The following is a description of a gene set: Mouse Gene Set: GOBP_ANIMAL_ORGAN_MORPHOGENESIS species: Mus musculus Morphogenesis of an animal organ. An organ is defined as a tissue or set of tissues that work together to perform a specific function or functions. Morphogenesis is the process in which anatomical structures are generated and organized. Organs are commonly observed as visibly distinct structures, but may also exist as loosely associated clusters of cells that work together to perform a specific function or functions., and this is the list of marker genes: Pou3f4, Tcf15, Rtn4, Bsx, Flt1, Tbx5, Rorb, Sox17, Myo6, Mir875, Barx2, Nrg3, Foxe3, Cxcr4, Palb2, Acvr1, Stat1, Dll4, Edn1, Pbx2, Srsf6, Kdr, Yy1, Vps51, Hoxb13, Uncx, Hesx1, Myc, Etv4, Hmx2, Fst, Gnat1, Fzd6, Myo3a, Adamts16, Wnt2b, Pcdha9, Foxo3, Ank, Hs2st1, Capn1, Tnfrsf11b (NCBI Gene Id 18383), Slc39a3, Xirp2, Sod1, Rara, Tbx3, Nfkb1, Crkl, Kdm6a, Kcnj8, Irx5 (Iroquois homeobox 5), Hoxa2, Tbr1, Pml, Ntng2, Acan, Dvl2, Gli3, Slitrk6, Pdgfa, Egln1, Wdr72, Krt13, Thrb, Pthlh, Odaph, Col5a1, Gnat2, Myf6, Gata3, Ncor2, Nrg1, Lims2, Grhl3, Spry1 (NCBI Gene Id 24063), Acta2 (actin alpha 2, smooth muscle, aorta), Pdgfc, Col13a1 (collagen, type XIII, alpha 1), Aqp1, Megf8, Grhl2, Rln1, Ajap1, Miat, Dchs1, Hoxd9, Met, T, Ctsd, Ilk, Six4, Ext1, Mef2d, 2610005L07Rik (NCBI Gene Id 436177), Agtr2, Slc26a4, Bmp2, Prdm1, Bbs4, Nle1, Plag1, Bcl11b, Mir217, Fras1, Lzts2, Atf2, Wnt3, Olfm3, Ntng1, Col6a1, Enam, Tead2, Men1, Esrp2 (epithelial splicing regulatory protein 2), Hs3st3a1, Gba1, Wnt11, Ssu2, Hoxa9, Apcdd1, Col2a1, Prkcb (NCBI Gene Id 319718), Stk40, Shh, Alpl, Fgfr1, Kcnq1, Pitx3, Rela, Trip11, Flvcr1, Mesp2, Ptk7, Traf6, Twist1, Id1, Cpb2, Th, Yap1, Wnt10a, Cav1, Cyp26b1, Nos3, Sfrp2, Man2a1, Fgfr2, Slit2, Hoxd3, Sulf2, Ereg, Slc1a1, Aldh1a1 (NCBI Gene Id 320092), Mapk8ip3, Foxf1, Rab33b, Cthrc1, Bmi1, Nrp2, Sox12, Btbd7, Npy1r, Stil, Sp1, Vps33b (vacuolar protein sorting 33B), Mir216a, Zfp950, Sema3c, Gjb6 (gap junction protein, beta 6), Lbx1, Gdf11, Neurod1, Ttn, Trpm1, Myh6, Clrn1, Hand2os1, Htt, Vax2os, Ccdc40, Tfap2a, Satb2, Foxn4, Cdkn2a, Lrig3, Ttc39c, Mir96, Dlx5, Rab23, Aldh1a2, Dvl3, Jag1, Mir20a, Fzd2, Ikzf1, Ncoa3, Myo3b, Megf11, Trex1, Ifitm5, Aplnr, Twsg1 (NCBI Gene Id 71539, twisted gastrulation BMP signaling modulator 1), Wnt16, Map2k2, Crygb, Prrx2, Plekha1, Hoxd13, Rpl38, Sparc, Il6, Ctsl, Hps1 (NCBI Gene Id 54334), Tymp, Hey2 (hairy/enhancer-of-split related with YRPW motif 2), Ntf5, Fam20a, Fgr, Lhfpl5, Ddr1, Bmp5, Col11a2, Dlg1, Foxp2, Kdm2b, Hottip, Lamb3, Chuk, Ccm2l, Mmp14, Mks1 (NCBI Gene Id 380718), Tnfsf11, Ceacam2, Lrig1, Sdk2 (NCBI Gene Id 75715), Gsc, Intu, Foxn3, Vegfc, Zfp335, Myf5, Cntf, Emx1, Ihh, Sp6, Tbx19 (T-box 19), Gli1, Med1, Nipbl, Ar, Has2, Insig1, Tnc, Fbn1, Foxa2, Ltf, Nab2, Ptprq, Stat6, Htr2b, Mdm2, Bmp6, Arl6, Tgfb3, Gata4, Pkd1, Esr2, Ifng, Pappa2, Lama1, Elf3, Wls, Foxi3, Pax8, Tnnt2, Cited2 (Cbp/p300-interacting transactivator, with Glu/Asp-rich carboxy-terminal domain, 2), Dlx2, Sox8, Pds5a, Fmn1, Psen1, Ntrk2, Ush2a, Gcnt4, C2cd3 (NCBI Gene Id 277939), Gcnt1, Zic3, Abr, Maged1, Cdsn, Lhx9, Itga2, Itgav, Mtor, Klk1b1, Hlx, Lama3, Eif4a3, Atf4, Rpgrip1l, Shank3, Lamc3, Dlg5, Naglu, Fbxw11, Tgm1, Tnf, Grk1, Rac1, Celsr1, Pafah1b1, Fli1, Prom1, P2rx7, Slc40a1, Tmtc3, Eva1a, Kras, Bcl2l11 (BCL2 like 11), Irx3, Msn, Tpm1, Alx4, Fancc, Sfrp4, Ppp1r13l, Myo5a, Matn1, Pbx1, Slc4a2, Cer1, Hoxa1, Ppargc1b, Mrtfb, Csrnp1, Tmem119, Hoxb5, Ceacam1, Mmp2, Chst11, Tgfbr3, Sirt6, Nab1, Col1a2, Bsg, Lef1, Pnpla6, Sall1, Samd7, Foxc1, Tdrd7 (tudor domain containing 7), Arid2, Pitx2, Adarb1 (NCBI Gene Id 76716), Clrn2, Meis2, Sufu, Tshz1, S1pr1, Wnk4, Rflnb, Hand1, Wnt6, Lamb1, Osr2, Rest, Mical2, Foxj1 (NCBI Gene Id 15223), Tmem215, Npnt, Thy1, Insr, Npy2r, Lipa, Atp6v1b1 (NCBI Gene Id 269766), Tfap2b, Sox5, Muc19, Ccl2, Ankrd24, Slc4a7, Ltbp3, Fancd2, Plau, Bmpr1a, Efnb2, Zfand5, Sfrp1, Rbm15, Bmpr1b, Klk4, Nherf1, Chad, Nf2 (NCBI Gene Id 18016), Nr4a3, Nr5a2, Sox11, Hs3st3b1, Mir23a, Mib1, Cdon, Sostdc1, Hnf1a, Atp2b2, Gata6, Pkp2, Col8a1, Meis1, Asb2, Tulp3, Hoxb8, Zfp157, Igf1r, Tgfa, Robo2, Cluap1, Asxl1, Cfc1, Tmed2, Slc8a1, Exoc4, Tet2, Six1, Rpgr, Ntn5, Trp63, Snai1 (NCBI Gene Id 98875), Hacd1, Sp7, Mir143, Pou2f1, Hoxa11, Pou4f3 (POU domain, class 4, transcription factor 3), Ascl5, Hoxd11, Dkk1, Hdac1, E2f4, Taf10, Mylk2, Nrl, Ahr, Cdh2, Rspo2, Ctns, Mmp16, Slc6a4, Tmem100, Atp8a2, Sec24b, Fgf10, Clic5, Tcap, Idua, Alx1, Mir182, Sox2, Rbm20, Rs1, Bmpr2, Twist2, Angpt1, Kdm5b (NCBI Gene Id 98723), Prkra, Zhx2, Dio3, Smtnl1, Cnga3, Serpinb5, Apc, Tgm2, Nrp1, Ovol2, Folr1 (NCBI Gene Id 14275), Parva, Cdc42, Ryk, Atg9a, Zfpm2, Thbs1, Wnt8a, Amelx, Col8a2, Ntn4, Pbrm1, Frs2, Foxg1, Chd7, Itpr1, Gabrr2, Axin1, Myh7, Fgl1, Perp, Sox4, Atoh1, Hmgn1, Dnah11, Eif4a3l2, Tecta, Olfm1, Ush1c, Gas1, Fat1, Tmt1a3, Ephb4, Nppc, Pdgfb, Sik3, Tbx2, Vsx2, Smad3, Errfi1, Plxnd1, Pten, Inppl1, Tbx1, Ctsz, Slc39a1, Mir145a, Otx2, Mapk14, Setdb2 (SET domain, bifurcated 2), Efemp1, Rbpms2, Npy5r, Col10a1, Tspear, Hoxb7, Foxf2, Lrrk2, Ptprm, Med12, Mir18, Ush1g, Lctl, Hyal1, Bmp10 (bone morphogenetic protein 10), Por, Comp, Sycp2, Cdx1, Sobp (NCBI Gene Id 78400), Actn3, Actg2, Wnt8b, Calb1, Pax9, Ripply1, Stau2, Mef2c, Lrp4, Pax4, Gja5, Acp5 (NCBI Gene Id 11433), Cela1, Slit3, Atg9b, Hhex (NCBI Gene Id 15243), Scube2, Triobp, Phlda2 (pleckstrin homology like domain, family A, member 2), Myl2, Tek, Mir452, Eda, Gzf1, Fat4, Synpo2l, Sav1, Egfr (NCBI Gene Id 13649), Fkbp1a, Hmga2, Inhba, Crb2, Foxe1, Fhl2, Recql4, Sapcd2, Igf2, Fgfr3, Sh3pxd2b, Magee2, Timeless, Stat5a, Hoxa7, Rxfp1, Hoxa4, Ephb2, Odam, Adgrg6, Tmem67, Col9a1, Edar, Wdr48, Kdm2a, Shox2, Tprn, Psen2 (NCBI Gene Id 98295), Pkd2 (polycystin 2, transient receptor potential cation channel), Grcc10, Lemd2, Klk5, Aqp3, Ndp, Grem1, Tfap2c, Jag2, Cst5, Hoxb1, Lamc1, Irx2, Snx10, Fbn2, Hpn, Spry2, Rarb, Gnas, Wnt5b, Dlx1as, Otx1, Alms1, Spag6l, Tmie, Mir124a-2 (NCBI Gene Id 723950), Tuba1a (tubulin, alpha 1A), Bcl2, Commd5, Id2, Tiparp, Cd44, Enpp1, Fgf1, Tmem107, Dscam, Mfap2, Mybpc3, Nr3c1, Hoxd8, Ring1, Bhlhe22, Rnls, Ski, Fgf8, Fosl2, Large1 (LARGE xylosyl- and glucuronyltransferase 1), Hyal2, Nkx2-3 (NK2 homeobox 3), Lama2, Hdac2, Ephb1, Cebpb, Nfib, Gaa, Zfpm1, Rxra, Zfp640, Pcnt, Hspg2, Frem1, Stim1, Prrx1, Nfix, Megf9, Dnaaf1, Lamb2 (laminin, beta 2), Myl3, Agtpbp1, Rp1, Fscn2, Col11a1, Itga8, Mir124a-1, Fgf9, Tead1, Tlx1, Axin2, Mdk, Samd11, Rhoa, Schip1, Pax2, Fasl, Tgfb1, Hcn1, T2 (brachyury 2), Itgb4 (integrin beta 4), Impg2, Mdm4, Rnf207, Bcar3, Mst1, Osr1, Serpine1, Map2k1 (NCBI Gene Id 26395), Bpnt2, Vegfa, Bhlhe23, Hoxc11, Fzd5, Mfsd2a, Mmp20, Gbx2, Phactr4, Ash1l, Plxna1, Pspn, Aspn, Mafb, Uty, Adamts1, Ccdc154, Fgf3, Ccn2, Klhl3, Pax5, Sdk1, Tsku, Ccdc103, Vangl2, Gpc3, Dvl1, Thra, Eln, Sema3a, Bbs10, Pdgfrb, Foxl2, Hif1a, Sos1, Rbp4, Gsk3a (glycogen synthase kinase 3 alpha, NCBI Gene Id 76828), Cd34, E2f5, Cdh1, Ryr1, Nog, Ftx, Otor, Ift80, Hoxb6, Gdf7, Fgf7, Pdgfra, Abcc9, Ptcd2, Ube4b, Hoxb9, Eya4, Frzb (NCBI Gene Id 20378), Ripor2, Npr2, Mfrp, Prickle1, Grxcr2, Wnt4, Etv5, Pim1, Nkx3-1, Lhx4, Ap3b1, Igf1, Mki67 (antigen identified by monoclonal antibody Ki 67), Nfic, Itga6, Csf1, Kat6a, Six3, Mir19b-1 (microRNA 19b-1), Epor, Ep300, Hes5, Nectin1, Gli2, Snai2, Pbx3, Nedd4, Mapk3, Ndst1, Ccdc39, Ctnna1, Btrc, Rpgrip1, Aqp6, Esrp1, Cyp7b1, Wnt1, Ppara, Lefty1, Bdnf, Hoxb2, Nsd2, Tmt1a, Efemp2, Irx4, Smad2, Gmppa, Dlx3, Bcr, Rpl13a, Tbx20, Ptf1a, Rdh13, Lims1, Sfrp5, Wnt10b, Cryaa, Bax, Cbs, Jhy (NCBI Gene Id 70989), Vax2, Slc24a4, Col3a1, Vhl, Xirp1, Zic1, Spef2, Ift172, Lrp6, Cdh23, Chsy1, Ripply2, Hoxa3, Mapk1, Poc1a, 3425401B19Rik, Aldh1a3, Wnt7b, Dync2i1, Kif3a, Gja1, Lrp5, Dhrs3, Col5a2, Sp5, Pbx4, Lgr4, Adamts5, Ctsh, Eya1, Areg, Ntn1, Ppp3ca, Sox1, Ambn, Ext2, Dag1, Prop1, Mfn2, Ahdc1, Foxa1, Rps6ka1, Fgf6, Igfbp5, Mmp13, Shroom2, Nkx3-2, Mfap5, Nodal, Stat3, Gcnt3 (NCBI Gene Id 72077), Akt3, Bmp7, Setd2, Rogdi, Hhip, Ift57, Treh, Gsx2, Wnt7a, Ptch1, Abca12, Relt, Ctnna2, Emp2, Gamt, Foxd1, Csf3r, Mesp1, Notch1, Smad6, Eif4a3l1, Fgfrl1, Mycn, Ift52, Wwtr1, Smad4, Cnnm4, Lrp2, Rarg, Itgb6, Robo1, Fam20c, Id4, Uchl5, Arl13b, Tcf7l2, Stra6, Epo, Asxl2, Carm1, Casz1, Fgf18, Rbpj, Phb2, Ctnnd1, Fjx1, Pou4f1, Pex7 (NCBI Gene Id 18634), Bcor, Src, Pde6c, Wdpcp, Mecom, Abi2, Sulf1, Fgfr4, Dmrt3, Nr2e3, Tgfbr1, Scrib, Tshr, Foxi1, Tnnc1, Csgalnact1, Arid1a, Hoxa13, Chrna9, Zeb1, Klhl10, Esr1, Duox2, Prkar1b, Jun (jun proto-oncogene), Otop1, Sox6, Dlx6, Sox3, Pax3, Ctnnb1, Lhx1, Bmp4, Runx2, Fkrp, Cpe, Fat3, Phospho1, Mir19a, Cyp27b1, Acvr2b, Lama5, Mir17, Prkci, Nkx2-5, Tab1, Bak1, Afdn (afadin, adherens junction formation factor), Col1a1, Msx2, Tnni3, Vdr, Trp53, Pdcd4, Thbs3, Ppp2r3a, Tacstd2, Il18, Hes1, Dsp, Acta1, Tnfaip3, Tbx4, Serp1, Col27a1, Gata5, Pgf, Acp4, Pdzd7, Eng, Id3, Smarcd3, Wdr19 (WD repeat domain 19), Prox1, Tgfbr2, Kif26b, Foxc2 (NCBI Gene Id 14234), Csmd1 (NCBI Gene Id 94109), Zfp422, Whrn, Vsx1, Actc1, Fzd1, Nectin3, Aqp5, Adamts9, Six2, Stc1, Arid5b, Nkx2-1, Tbx18, Acvr2a, Epha2, Zmpste24, Pax7, Ankrd11, Nek8, Gak, Tcirg1, Pax1, Tmt1a2, Cul3, Fuz (NCBI Gene Id 70300), Smarca4, Prkx, Alx3, Tmem59l (NCBI Gene Id 67937), Adm, Greb1l, Ppp1r35, Gdnf, Flna, Hey1, Adam15, Fgf4, Bbs2, Rom1, Srf, Ryr2, Chrna10, Wt1, Tenm3, Prkar1a, Ift88, Alpk2, Cftr, Ror2, Hipk2, Ly6e, Pax6, Hoxd4, Dlx1, Hoxc4, Hoxa5, Ankrd1, Acvrl1, Kcnq4, Tulp1, Smad7, Crb1, Adamts19, Glg1, Plod3, Insig2, Foxo1, Strc (stereocilin), Mir1a-2, Bloc1s5 (biogenesis of lysosomal organelles complex-1, subunit 5, muted), Slc4a10, Myo15a, Xbp1, Phex, Irx1, Rho, Mthfd1l (NCBI Gene Id 77586), Heyl, Hoxc13, Tnni1, Dscaml1, Cflar, Wnt2, Ntn3, Pcgf2, Cabp4, Dicer1, Cfh, Casp6, Nfatc1, Smo, Pls1, Noto, Hoxc9, Nckap1, Stox1, Ahi1, Hoxb4 (NCBI Gene Id 15412), Pkhd1, Emx2, Lamc2, Tcf21, Gng5, Tbc1d20, Mir183, Dll1, Dspp, Smarcc1, Fzd3 (frizzled class receptor 3), Cert1, Scx, Ift140, Nphp3, Sp3, Ctnnbip1, Wnt5a, Grxcr1, Nlrp5, Tifab, Bbs1, Pgr, Ttc8, Agtr1b, Cep290, Hoxc8, Slc44a4, Ednra (endothelin receptor type A), Hgf, Tgfb2, Dmp1, Polb, Fgf2, Hmx3, Notch2, Agt, Tcf7, Lif, Serpinh1, Hoxd10, Wwox, Mir216b, Isl1, Cul1, Erbb4, Ift122, Tshz3, Flrt2, Gmnn, Mdfi, Zmiz1, Meis3, Agtr1a, Hnf1b, Adprhl1, Neurog1, Mkks, Heg1, Gsk3b, Tspan12, Cited1, Nf1, Wnt9b, Tbx15, Gfi1, Cav3 (caveolin 3), Sgpl1, Ccl11, Hipk1, Myo7a, Ptn, Hoxb3, Gata2, Efna1, Wnt3a, Fem1b, Sox9, Asxl3, Edaradd, Msx1, Pcdh15, Mir92-1, Hmga1, Ngfr, Mylk, Amtn, Slc12a2, Trpv4, Hand2, Galnt3, Gngt1, Irx6, Dlc1 (deleted in liver cancer 1), Foxh1, Ccn1, Cplane2, Rflna, Rdh10, Lhx8, Dzank1, Smpd3, Wnt9a, Poc5